Given this list of marker genes Septin2, Phtf2, Thrap3, Tmem60, 1700028E10Rik, Gm10222 (predicted gene 10222), Vps37c, Scrib, Gpbp1, Hnrnpl, Stap2, Tut7, Thap4, Eif2ak3, Mir6236, Mprip, Kat7, Rpl27, Gm5272, Gm11520, Rps27l, Chka, Hexim2 (NCBI Gene Id 71059), Dmtf1, Vps35l, Zfyve21, Nectin2, Mief1 (NCBI Gene Id 239555), Stk40, Rubcn, Sowahc, Sp1 (trans-acting transcription factor 1), Xrcc3, Flad1, Gm15564, Cpt2, Zfp760, Camkmt, Atg4b, Klhl9, Dcaf7, Ank1, Zfp945, Prepl, Septin10, Hdlbp, Slc39a3, Sp2, here is a description of the gene set: species: Mus musculus from publication Yevshin I, Sharipov R, Kolmykov S, Kondrakhin Y, Kolpakov F (PMID 30445619) Genes containing one or more binding sites for (Elk3) in their promoter regions (TSS -1000,+100 bp) as identified by GTRD version 20.06 ChIP-seq harmonization. Mouse Gene Set: ELK3_TARGET_GENES